Given this list of marker genes CCNA1, TNRC6A, CXCL5, KLF6, VEGFA (NCBI Gene Id 7422), FERMT1, RNF152, CYREN, CSNK1D, DENND2B, CD274, SLC9A1, TIMP1, TNRC6B, PIAS1 (NCBI Gene Id 8695), GRHL2, ZNF608, CRIM1-DT (CRIM1 divergent transcript), PLAUR, FAM83A, UPP1, TMEM45B, PALMD, NFIB, B3GNT5, LRRC8C, PLXNA2, CALM2 (calmodulin 2), MALL, MAP1LC3B, HBEGF, DLST, HPSE, ABCA1, ITGA2, TIA1, CASP2, STAG3L1, LPAR2, FOXQ1, LIF, FLNB, GJB3, TALAM1, ADRB2, KDM7A, DUSP6, IL13RA2, MFAP2, TMEM154, INPP1, ADAMTS5, MIRLET7BHG, EGR1, ZNF827, CD55, GPAT3, MYDGF, ULBP2, EFNB1, CXCL2, LATS1, MBOAT2, DLL1, KCNN4, LRP8, ZBED2, DNAJC6, GK, SDC4, KMT2C, SPRY4, MYD88 (NCBI Gene Id 4615), SOCS1, COL27A1, NIPAL1, ARG2, CYP2R1, IL1B, SREK1IP1, PVR, NAV3, MXD1, CCL20, PIM1, ITPRIP, GLCCI1, ADAMTS15, ARHGAP25, PTPRE, OXSR1, KCNK1, LINC-PINT, LRIG3, JUNB, SEMA4C, SAMD8, LYN (LYN proto-oncogene, Src family tyrosine kinase), CASP1, GJB5, C2CD5, SRRM2, ELK3, TUBA4A, MCL1 (MCL1 apoptosis regulator, BCL2 family member), LHFPL2, MEG3, ODC1, CLCF1, TOP1, NOLC1, PNLIPRP3, MDH1, ARHGEF9, MAST4, ZKSCAN8, MED25, SESN2, TRIB1, C6orf141, MRGPRX3, PHACTR4, HNRNPH1 (NCBI Gene Id 3187), BCL6, PPBP, EPHA2, GDF15, ZFP36, PPIF, KDM6B, NT5E, FGFR2, ERN1, PTHLH, IL1A, SKP2, IRX2, FOS, GAS1, TNS4, MFSD2A, G0S2, ZNF273, LDLR, EPHA4, EHD1, PNPLA8, TCF7L2, DENND2C, ELOVL7, STX1A, CYP1B1, MAP7D1, NFKBIZ, ANGPTL4, CXCL1, BMP2, FN1, MTUS1, TNFRSF10A, HRAS, IER3, SERPINB3, AHNAK2, FOSL1, IER2, VANGL2, KLF5, TTC8, ATP2B1, ACOT7, HK2, CDCP1, HOXC6, S100A6, DUSP1, HMGN3, SLC2A3 (NCBI Gene Id 94827), TMTC3, NAP1L1, TFPI2, ARHGAP27, COL12A1, GTPBP2, PI3, SH2D5, TNFRSF12A, SMTN, RAPH1, SDC1, SFN, PRNP, TENT5B, TNFRSF10B, KANK4, UAP1, GLTP, PMS2P8, H1-4, TGFA, MICAL2, CSNK1E, SYNE3, XIST, DUSP4, TSC22D1, PHLDA2, MID1, SLC20A1, CXCL8, CALU, CHST11, CCNL1, RUNX1, SEMA4B, LGALS8, SESN3, TRIM22, DUSP5, PIK3CD, LRRFIP1, PNMA2, TGFB2, BMAL2, SLC16A3, FAM110C, TOR1AIP1, FGFBP1, FBXO9, EREG, H2AC6, DDX17, CYP27B1, NAMPT, IL11, PTX3, PPP1R15A, SERPINB2, TBX3, CXCL3, LRAT, MMP14, RRP9, FLRT3, ITPR3, PDGFA, NDRG1, MTCL1, PTGS2, SLC6A15, SERPINB1, ADAM8, here is a description of the gene set: The development of an oncogenic state is a complex process involving the accumulation of multiple independent mutations that lead to deregulation of cell signalling pathways central to the control of cell growth and cell fate. The ability to define cancer subtypes, recurrence of disease and response to specific therapies using DNA microarray-based gene expression signatures has been demonstrated in multiple studies. Various studies have also demonstrated the potential for using gene expression profiles for the analysis of oncogenic pathways. Here we show that gene expression signatures can be identified that reflect the activation status of several oncogenic pathways. When evaluated in several large collections of human cancers, these gene expression signatures identify patterns of pathway deregulation in tumours and clinically relevant associations with disease outcomes. Combining signature-based predictions across several pathways identifies coordinated patterns of pathway deregulation that distinguish between specific cancers and tumour subtypes. Clustering tumours based on pathway signatures further defines prognosis in respective patient subsets, demonstrating that patterns of oncogenic pathway deregulation underlie the development of the oncogenic phenotype and reflect the biology and outcome of specific cancers. Predictions of pathway deregulation in cancer cell lines are also shown to predict the sensitivity to therapeutic agents that target components of the pathway. Linking pathway deregulation with sensitivity to therapeutics that target components of the pathway provides an opportunity to make use of these oncogenic pathway signatures to guide the use of targeted therapeutics. from publication Bild AH, Yao G, Chang JT, Wang Q, Potti A, Chasse D, Joshi MB, Harpole D, Lancaster JM, Berchuck A, Olson JA Jr, Marks JR, Dressman HK, West M, Nevins JR (PMID 16273092) Human Gene Set: BILD_HRAS_ONCOGENIC_SIGNATURE studied in species Homo sapiens Genes selected in supervised analyses to discriminate cells expressing activated HRAS oncogene from control cells expressing GFP.